Given this list of marker genes RPA1, F2RL2, CFAP53, SYNM, EHD3, GCNT2, HEMGN, PHETA2, GPC6, ZMAT2, GPRIN2, C1orf105, MANF, TMEM123, CLNK, MRPL1, CXCR6, PSPN, MIXL1, TP63, GLRB, LGR6 (leucine rich repeat containing G protein-coupled receptor 6), CAMTA2, CPA1, APOE, OCA2, FXYD4, RPAP1, PAX9, GPR12, SFT2D1, SLC34A3, SLC6A18, HNF4G, HOXB6, TXNDC2, UNC80, NELFA, PLA1A, USP14, OSMR, NSMCE1-DT, ZNF414, PAPPA2, PTTG1, KIF17, TMUB1, PRR11, CTH, IRF5, SNCB, CXXC5, KCNS2, MINDY1, ARHGEF28, BLOC1S3, E2F4, FMNL3, TEAD4, RAB40C, ZC4H2, ROPN1, MBOAT1, DAP3, MYOZ1, LIPC, DACH2, HSPB7, PNP, CPXM2, NRTN, ADAMTSL5, CES4A, GPKOW, DENND2D, KIFC1, RPL39L, IL4R, PMEL, THADA, DIPK1A, ACSM5, IGHG1, EFCAB2, CEP126, SREBF1, MYO9A, WDR18, NSMCE1, CHST11, THBS2, TSSK4, CDC42EP3, KRTAP2-4, WDR81, SMOC1, TMIGD1, SRPK3, SLA2, PLCXD1, RNASE2 (ribonuclease A family member 2), MDFI, CYP8B1, C1orf50, FBXL18, RNF217, PM20D1, SLC16A14, CDCP1, ANKH, BPGM, PID1, ACSL3, ZSWIM5, TMEM134, SYT11, PCDHB1, FAM107A, SCGB3A1, HBA2, TAF3, B4GALT2, VRK2, PCDH20, DYNC2LI1, MEGF6, GLIS1, EPHX2, PLA2G10, SPINT4, RASA2, LCK, IGSF21, NKX3-2, BEND4, DRC1 (dynein regulatory complex subunit 1), ATP6AP1, VAT1L, TMEM229A, LRIG1, GRP, QNG1, XKR8, XCL1, SPATA24, CHTF8, NFATC2, KITLG, LONRF3, PRIM2, C2CD4C (NCBI Gene Id 126567), HMGCS1, BPIFB1, PTPRC, ZNF354B, DNAAF11, CHD5, RPL9, CLIC1, C6orf15, RHOA, PRDM14, RORA, DIO2, IPCEF1, EMX1, CHAC1, ATOH8, CHRNG, PIK3AP1, ENTREP1, ABCG8, RERG, ARHGAP28 (NCBI Gene Id 79822), UBE2U, PTPN4, PAG1, FSCN3 (fascin actin-bundling protein 3), NDRG1, DDI1, HOXA5, MS4A8, WNT8A, LIMD2, C6orf132, CD83, ASB6, CCDC24, RAD51C, SLC22A14, ZNF511, NSG1, GAREM2, AP1M2 (NCBI Gene Id 10053), GRPR, LURAP1, DEXI, ARPC3, LPIN3, FRMPD2, here is a description of the gene set: from publication Chang WL, Coro ES, Rau FC, Xiao Y, Erle DJ, Baumgarth N (PMID 17237394) studied in species Homo sapiens Genes up-regulated in lymph node B lymphocytes with influenza infection: wildtype versus IFNAR1 knockout. Influenza virus infection-induced gene expression changes of regional B cells are mediated at least in part through type I Interferon: Our objective is to determine whether the influenza virus-infection induced gene expression changes in regional lymph node B cells are facilitated at least in part through type I interferon. Our specific aim is to compare the gene expression profile of highly FACS-purified B cells in the regional lymph nodes of wildtype and IFNR-/- mice prior to and 48h following infection with influenza virus infection and to contrast this expression profile with that of FACS-purified wildtype B cells activated in vitro with IFN-beta +/- anti-CD86 for 12h. Human Gene Set: GSE3203_WT_VS_IFNAR1_KO_INFLUENZA_INFECTED_LN_BCELL_UP